Given this list of marker genes NKX2-5, TBX20, HEY2, FOXH1, GATA3, SOX4, TGFB2, SEMA3C, PPP1R13L, BMPR1A, ZFPM2, GATA4, SMARCD3, MIR17HG, HAND1, BMP4, JAG1, CHD7, HAND2, NOTCH1, ISL1, here is a description of the gene set: Human Gene Set: GOBP_CARDIAC_RIGHT_VENTRICLE_MORPHOGENESIS species: Homo sapiens The process in which the right cardiac ventricle is generated and organized.